The following is a description of a gene set: species: Homo sapiens Genes down-regulated in spleen follicular B lymphocytes: wildtype versus IRF8 knockout. Human Gene Set: GSE24972_WT_VS_IRF8_KO_SPLEEN_FOLLICULAR_BCELL_DN from publication Feng J, Wang H, Shin DM, Masiuk M, Qi CF, Morse HC 3rd (PMID 21178004) Conditional IRF8 KO mice (mice with a conditional allele of Irf8 crossed with CD19-Cre mice) showed increased numbers of both Gene expression data spleen marginal zone (MZ) and Gene expression data spleen follicular (FO) B cells compared to control mice. To evaluate gene expression patterns that distinguished FO or MZ B cells derived from conditional KO and control mice, we used Affymetrix GeneChip® Mouse gene 1.0 ST Array., and this is the list of marker genes: RAD51D, ESRP1, SNRPF, ARMC7, CLPTM1, C12orf75, PKMYT1, AP5B1, APBA2, CKAP2L, VAV2, TBC1D31, SPIN1, BTK, CXCR5, RNASE6 (ribonuclease A family member 6), FUT7, SCD, RELB, POC1A, SHC1, ASB8, KAZALD1, SLC11A1, FADS2, BTBD1, EYA2, COX6A2, ETS1, GIT1, SREBF2, SNX11, KNTC1, NYX, CCT6A, LHFPL2, ARMCX6, SUSD6, DCST2, IARS2, XPO1, AGAP2, ZC3HAV1, PDGFA, HSPA4L, FOXO3, PRRT1, BANK1, NAXE, B3GLCT (beta 3-glucosyltransferase), THOC1, SLC7A14, NRROS, SPATA13 (spermatogenesis associated 13), FBXW9, PRAM1, UBL4A, CRELD2, PAK4, TTL, CDCA7L, IKBKE, ATP6V1E1, NUP205, ZBTB44, ASF1B, TKT, ITGA1, HNRNPLL, GIMAP1, FLII, DOCK2, INKA2, LONP2, SMYD3, NSUN2, ILVBL, TRPM1, NUSAP1, SAPCD2, PRELID3B (PRELI domain containing 3B), KCTD14, C11orf54, CREG2, TMEM131, CHMP7, RGS16, PIGN, G6PD, PPP1CC, SPACA9, SORL1, MDM2, CYFIP2, CD300C, C15orf61, MID1IP1, C1orf105, MBD3, GFRA1, ALAD, TENM4, TRIM8, DTNBP1, PTK7, COX6C, ILF3, HRG, B4GALT5, RFX8, ABI3, TRIP13, CIT, AHCYL2, PSMB9, CRB3, MRI1, KDM2B, USP42, DRAM1, CCDC9, CSF2RA, KDM1A, NAB2, CHST12, CD300LB, AMBP, LATS1, TCF3, FUOM, NAP1L1, BLOC1S5, CFP, RPS6KA3, PIGC, TST, TTC9C, NXPE2, MAP6, TMEM184B, SYNGR1, NAA35, PRIM1, PTPRC, OCSTAMP, RBPMS2, UNC93B1, SERPINB12, SPI1, EBI3, NFKB2, PLPP3, ERF, TTLL12, NUP107, RCOR2, BEST1, PTTG1IP, GAS2L3, UBE2C, TNFAIP3, PLPP5, SLIRP, CDKL3, ENO1, CEMIP2, NIPSNAP3A, ABI2, PIGP, TOPBP1, SLC48A1 (NCBI Gene Id 55652), TMEM106C, ATXN10 (NCBI Gene Id 9490), HIVEP3, TPI1, PYCARD, AHI1, ABR, MCOLN2, PCSK4, PIK3AP1, MAST2, STAU2, DNAJB14 (DnaJ heat shock protein family (Hsp40) member B14), SDHC, KCTD11, SIMC1, FMNL3, LXN, HM13, SKAP1, NUP133, HLA-DMB, SEC22B, BCL2, JADE3, SDC3, CD79B, CFB, MAGED1